The following is a description of a gene set: Mouse Gene Set: GOBP_AUDITORY_BEHAVIOR The behavior of an organism in response to a sound. species: Mus musculus, and this is the list of marker genes: Drd2, Abl2, D130043K22Rik, Foxp2, Slc1a3 (solute carrier family 1 (glial high affinity glutamate transporter), member 3), Stra6, Nrxn2, Shank3, Htt, Tifab, Nrxn1, Slitrk6, Neurog1, Cntnap2